Given this list of marker genes SMPD3, SMPDL3A (sphingomyelin phosphodiesterase acid like 3A), SMPDL3B, SMPD4, SMPD2, SMPD1, ENPP7, PRKCD, here is a description of the gene set: Human Gene Set: GOBP_SPHINGOMYELIN_CATABOLIC_PROCESS studied in species Homo sapiens The chemical reactions and pathways resulting in the breakdown of sphingomyelin, N-acyl-4-sphingenyl-1-O-phosphorylcholine.